Given this list of marker genes GRIK4, DLG4, GRIK2, CALM1, DLG3, GRIK5, NCALD, GRIK3, GRIK1, DLG1, here is a description of the gene set: species: Homo sapiens Kainate receptors that are assembled with subunits GRIK1-5, are Ca2+ permeable if GRIK1 and GRIK2 are not edited at the Q/R or other sites.<br>These channels permit Ca2+ upon activation by glutamate or other agonists. part of: Ionotropic activity of kainate receptors Reactome Pathway: Activation of Ca-permeable Kainate Receptor